Given this list of marker genes SERPINB13, SAV1, ZFP36, GSN, PIAS4, ZFP36L1, SFRP4, MIR4516 (microRNA 4516), here is a description of the gene set: Any apoptotic process in a keratinocyte. A keratinocyte is an epidermal cell which synthesizes keratin and undergoes a characteristic change as it moves upward from the basal layers of the epidermis to the cornified (horny) layer of the skin. Human Gene Set: GOBP_KERATINOCYTE_APOPTOTIC_PROCESS studied in species Homo sapiens